Given this list of marker genes CPXM2 (carboxypeptidase X, M14 family member 2), CTXN3, TMCC1, NLK, UCP2, PRAME, MAP4K4, PCNX3, KRTAP3-3, HOXB3, CTNS, FADS3, MGAT3, MGP, PEG3, STOX1, C1RL, ZYG11B, TTC23L, CBL, CALHM5, NPAS3, TRIM7, SEMG1, GPR82, CTPS2, VAMP1, MIR34A, SH3RF3, GNA11, KCTD18, ERO1B, HOXA1 (NCBI Gene Id 3198), ETNK2 (ethanolamine kinase 2), SERPINB5, FOXO4, PUDP, MMEL1, MYO3B, CABP1, DPPA2, LRRC30, SULT1C2, SAG, CTCF, PPP1R37, THBD, ME2, PTPRE, DOP1B, SLC7A14, LINGO2, LMTK2, HOMEZ, VGLL3, CELF5, MADCAM1, LRRTM3, SPON2, KRTAP12-1, SPINK6, TCEAL5, NMRK1, EFR3B, TAAR2, HAPLN2, PIGT (phosphatidylinositol glycan anchor biosynthesis class T), EGFL6, TRAM1, HTRA1, KRT25, RBM7, SOSTDC1, TTC24, PDE7A, SCRT1, SLC25A37, CRISPLD1, CD300LB, SHISA6, FDXACB1, FOXL1, PTPRO, FBXO3, LMBR1 (limb development membrane protein 1), ANKRD33, RARB, MFSD1, RAB33B, POTEG, CNGA1, ACSM1, C3orf22, SLC18A1, ADGRG7, HS3ST3B1 (NCBI Gene Id 9953), TRPV5, FUT1, DEGS2, NOVA2, ACER1, ARHGAP26, S100G (NCBI Gene Id 795), CES3, HAS1, ZC3H4, AKAP8L, FRMPD3 (FERM and PDZ domain containing 3), DISP2, FBP1, POU5F1 (NCBI Gene Id 7934), PRPF6, CACNA1S (NCBI Gene Id 779), ADAMTS9, SCAMP5, RBM43, STAP1, FGF22, RERG, PRAMENP, PITX1, IL17C, ANKRD2, NPHP3, OPRL1, FEZ2, TSSK4, here is a description of the gene set: To investigate the early host response triggered by three different strains of Trypanosoma cruzi at a local infection site, changes in host gene expression were monitored in a murine intradermal infection model using Affymetrix oligonucleotide arrays. Robust induction of IFN-stimulated genes (ISGs) was observed in excised skin 24 hours post-infection where the level of ISG induction was parasite strain-dependent with the least virulent strain triggering a muted IFN response. Infection of mice immunodepleted of IFNγ-producing cells or infection of IFNγ-deficient mice had minimal impact on the IFN response generated in T. cruzi infected mice. In contrast, infection of mice lacking the type I IFN receptor demonstrated that type I IFNs are largely responsible for the IFN response generated at the site of infection. These data highlight type I IFNs as important components of the innate immune response to T. cruzi the site of inoculation and their role in shaping the early transcriptional response to this pathogen. We used microarrays to detail the local host transcriptional response to intradermal T. cruzi infection in WT mice and mice depleted of NK cells, or deficient in IFN-gamma or type I IFN responses. Additionally we compared the local host-transcriptional response generated to infection with 3 different strains of Trypanosoma cruzi (Y, Brazil, and G). species: Homo sapiens from publication Chessler AD, Unnikrishnan M, Bei AK, Daily JP, Burleigh BA (PMID 19201883) Genes down-regulated in skin from: wildtype (BALB/c) versus IFNG knockout. Human Gene Set: GSE13522_WT_VS_IFNG_KO_SKIN_DN